Given this list of marker genes Hrh3, Adora2b, Agt, P2ry12, Plcd1, Adora3, Nisch, Ffar3, Adora2a, Kcnb1, Oxtr, Agtr2, Ghsr, P2ry1, Chrna7, Comt, Crh (corticotropin releasing hormone), Crhr2, Ptgs1, Stx1a, Ptger3 (prostaglandin E receptor 3 (subtype EP3)), Oxt, here is a description of the gene set: The regulated release of norepinephrine by a cell. Norepinephrine is a catecholamine and it acts as a hormone and as a neurotransmitter of most of the sympathetic nervous system. Mouse Gene Set: GOBP_NOREPINEPHRINE_SECRETION species: Mus musculus